The following is a description of a gene set: species: Mus musculus Any process that activates or increases the frequency, rate or extent of growth of an organ of an organism. Mouse Gene Set: GOBP_POSITIVE_REGULATION_OF_ORGAN_GROWTH, and this is the list of marker genes: Mapk1, Igf2, Mapk14, Fgfr2, Ybx3, Prox1, Zfpm2, Ccnb1, Ep300, Hey2, Edn1, Nrg1, Hamp2, Sirt1 (NCBI Gene Id 93759), Smo, Arx, Gata4, Fgf8, Hamp, Slc25a4, Bmpr1a, Sash3, Cdk1, Akap6 (NCBI Gene Id 238161), Agt, Notch1, Trip10, Tgfbr3, Ddx39b, Acacb, Akt1, Pim1, Hlx, Mtor, Gli1, Tbx20, Bmp10, Tbx2, Cacna2d2, Il7, Yap1, Fgfr1, Fdps, Parp2, Pin1, Tbx1, Igf1, Serp1, Mef2c, Pin1rt1, Wnt2, Rbpj, Ccnd2, Rag2, Ccn4, Wt1, Nr3c1, Adrb1, Ncam1, Fgf9 (NCBI Gene Id 252883), Erbb4 (erb-b2 receptor tyrosine kinase 4), Tbx5, Fgf2, Gata6